Given this list of marker genes TFIP11, ZNF226, DCAF7, ARHGAP33 (Rho GTPase activating protein 33), TIPRL, C17orf75, PTPRC, BCL2L2, VPS26A (NCBI Gene Id 96725), NUP43, HLTF, PTPRE, NEK7, ZWILCH, APOBEC3G, KEAP1 (NCBI Gene Id 9817), ZMPSTE24, XCL1, RNF4, UBXN4, CBLB, RFX7, RAB5A, HIPK2, CREB3L2, CDC42EP3, RNF34, UBE2W, EOLA2, ITCH, CDK12, NCAM1, LASP1, CTSO, PTPN22, STAMBP, PSME4 (proteasome activator subunit 4), ATP10D, SNX5, TINF2, GSN, CPD, MLEC, C1orf174, STAU2, TNFRSF1A, SMAD5, NARF, UBB, FAM13B, TOX, KLRD1, RAD23B, TMEM87A, SEL1L, ALOX5AP, ACSL3 (acyl-CoA synthetase long chain family member 3), APOBEC3C, INPP1, PPP1R3D, ARAP2, SUCLA2, LARP7, TXNDC9, POLE2 (DNA polymerase epsilon 2, accessory subunit), SART3, WIPF1, LPIN1, UCK2, AP5M1, ATP6V1A, TM6SF1, MTG1, LRCH3 (NCBI Gene Id 84859), BARD1, PHF21A, PCTP, NDUFAF1, RRAS2, PIGB, TARDBP, TBL1X, RHBDF2, NUP107, AOAH (NCBI Gene Id 313), VPS41, MMUT, SLFN12, UTP14C, IDH1, NCR1, BLM, TRIP12, ZNF12, ALAS1, PDCL, ZNF264, S1PR5 (sphingosine-1-phosphate receptor 5), TRIP4, SNAP29, UNC50, TAPBPL, ZNF544, DUSP22, MCF2L2, CLTC, NUP133, TBC1D31, YARS1 (NCBI Gene Id 8565), TCF12, PSPC1, KPNA3, INTS6, ZDHHC17, AFG2B, C2CD3, PHTF1, FMR1, GALNT7, NPC1, KIFAP3, ARHGEF12 (Rho guanine nucleotide exchange factor 12), SLC27A3, SEPHS2, GTF2E1, SECISBP2L, STX4, POLD3, KRIT1, DCUN1D1, ENPP4 (NCBI Gene Id 57011), PON2 (paraoxonase 2), FAIM, CHST12, IGF2R (insulin like growth factor 2 receptor), KIR2DL4, PLAGL1, RNF115, BAZ2B, AREL1, BIRC2, UTP11, CTBP2, RAC1, VPS4B, YPEL1, ASPM, STOM, ZFAND6, PRKAR1A, RAD50, MRFAP1L1, TIMM8B, PPP1R8, LAT2, CTR9, STK39, PLCG2, MRPS22, USP8, STX7, ZFYVE16, MED20, KLHDC10, ZSCAN26, HSPA1A, LAMP1, IL18RAP, TRIM58, TUT7, RSF1, AQR, TRAF5, TNPO1, SEC24C, COPB2, NRF1, PIGV, ABHD2, COPB1, DDX23 (NCBI Gene Id 9416), TOR1B, FEZ2, HARS2, THOC2, CLIC3, YES1, ATG12, GALNT3, C5orf15, GGNBP2, KMT5B, PLEKHO2, GMEB1, ACTR8, MCTP2, MED8, STX6, here is a description of the gene set: Human Gene Set: GSE22886_NAIVE_CD4_TCELL_VS_NKCELL_DN from publication Abbas AR, Baldwin D, Ma Y, Ouyang W, Gurney A, Martin F, Fong S, van Lookeren Campagne M, Godowski P, Williams PM, Chan AC, Clark HF (PMID 15789058) Genes down-regulated in comparison of naive CD4 T cells versus unstimulated NK cells. species: Homo sapiens Immune cell-specific expression is one indication of the importance of a gene's role in the immune response. In order to identify such patterns, we set out to broadly profile gene expression in a variety of immune cells.